Given this list of marker genes UNC13B, PPFIA2, SYT1, VAMP2, SLC18A2, SNAP25, STXBP1, PPFIA3, SYN2, RIMS1, TSPOAP1, PPFIA1, CPLX1, STX1A, SYN3, SYN1, RAB3A, PPFIA4, here is a description of the gene set: species: Homo sapiens Serotonin Neurotransmitter Release Cycle Human Gene Set: REACTOME_SEROTONIN_NEUROTRANSMITTER_RELEASE_CYCLE